The following is a description of a gene set: Human Gene Set: MIR516A_3P_MIR516B_3P from publication Chen Y, Wang X (PMID 31504780) Genes predicted to be targets of miRBase v22 microRNA hsa-miR-516a-3p, hsa-miR-516b-3p in miRDB v6.0 with MirTarget v4 prediction scores > 80 (high confidence targets). studied in species Homo sapiens, and this is the list of marker genes: LIN7A, SPRED1, RSU1, XBP1, ZNG1E, SEPTIN6, CTLA4 (NCBI Gene Id 3411), TCF4, PIAS2, RIMBP2, HEXIM1, ZNF385B, SFT2D2, MYOC, CEBPG, PLEKHG7, ASXL2, PDE1A, HAT1, RHPN2, SYT14, ARSF, PRAMEF13, TFAP2A, ZNF441, PCDH7, KIF21B, CHRNA6, NKIRAS2, STK32B, PPM1F, HCFC1, TRIM32, PIAS4, GRIA4, ITPRIP, PLXDC1, DTNA, GHR, MED23, TRMT9B, GRIK3, CTIF, MRPL34, S100B, DPH3P1, NKX2-8, ABCB5, RC3H2, CSF1, IFI27L1, ABHD17A, DPP6, CREB5, EGFLAM, BAP1, KCNIP1, REV1, ZNF26, OSBP2, PRKCA, SRSF2, SLMAP, PAX3, CCDC93, AGO1, SFPQ, MEX3B, DLST, PCNP, MRPS7, JAZF1, SLCO3A1, VANGL1, ECHDC1, CREBRF, GPM6B (glycoprotein M6B), CRLS1, LBH, YWHAH, ESYT3, CIPC, SLC30A4, TET3, COMMD9, F3, GXYLT1, VHL, VPS53, ATF7, FCHO2, SDK2, SH3GL2, SYT4, COL6A6, SLC23A1, CBFA2T3, RPS3, PEG10, CLASP1, SULF1, CFAP410, ZNF250, HSF2, RUNX3, TNS3, HOPX, SLC36A4, ZNF367, KLHL3, SYT1, APH1B, PANX1, RTEL1, TRABD2B, BLCAP, JMY, SOBP, TMEM164, NSF, PABIR3, ANKFY1, CADM2, INKA2, NR2E1, WWOX, FAM120C, ZFAND5, PTPRN2, ONECUT2, MGAT5, CHIC1, SIAH1, GALK2, GFOD1, SFMBT1, PIP4K2A, CTCFL, PRAMEF1, PLA2G4E, CERS6, ATP6V1D, PPWD1, CCDC14, PI4K2A, CDHR3, KLF5, NPNT, MTX3, CNOT3, CHD2, APOLD1, SLC6A6, CCNH, SDK1, ALPK3, TUB, ZBTB25, DIAPH1, NETO2, ASIC1, ELL2, KIAA1549, JDP2, DUSP5, ZC2HC1C, RIMS2, GAGE1, PRR5L, B3GNTL1, PRP4K, PRAMEF14, GRID2, STAT4, ZNF440, PANK2